The following is a description of a gene set: species: Homo sapiens TGF-beta receptor signaling activates SMADs Human Gene Set: REACTOME_TGF_BETA_RECEPTOR_SIGNALING_ACTIVATES_SMADS, and this is the list of marker genes: USP15 (ubiquitin specific peptidase 15), FBN1, PPP1CC, STRAP, SMAD7, SMURF1, PPP1CB, ZFYVE9, UCHL5, STUB1, TGFBR3, TGFBR1 (transforming growth factor beta receptor 1), SMURF2, NEDD8, RPS27A (ribosomal protein S27a), ITGB6, PPP1CA, MTMR4, ITGAV, LTBP3, SMAD3 (SMAD family member 3), BAMBI (BMP and activin membrane bound inhibitor), ITGB1, LTBP1, ITGB8, TGFBR2, LTBP4, SMAD2, PMEPA1, XPO1, UBC, ITGB5, UBB, PPP1R15A, UBE2M, FKBP1A, ITGB3, TGFB1, NEDD4L, UBA52, SMAD4, LTBP2, FURIN, TGFB2, TGFB3, ITGA8, CBL